The following is a description of a gene set: Human Gene Set: HP_URINARY_INCONTINENCE Urinary incontinence Loss of the ability to control the urinary bladder leading to involuntary urination. studied in species Homo sapiens, and this is the list of marker genes: MORC2, AP5Z1, CABP4, HTRA1 (NCBI Gene Id 5654), GALNT2 (NCBI Gene Id 2590), PIK3CA, SIGMAR1, FUS (FUS RNA binding protein), DNMT1, HPSE2, SPAST, SMO, CLCNKB, DEPDC5, SLC44A1, CACNA1H, PANK2, SLC2A1, IGHMBP2, CAPN1, NOTCH3, NOTCH2NLC, ARSA, MTMR14, SYNE1, GABRB3 (gamma-aminobutyric acid type A receptor subunit beta3), WASHC5, KCND3, ATXN10, AKT1 (NCBI Gene Id 207), SBF1, KIF5A, KMT2B, FITM2, SMARCB1, TRIO, HMBS, ZEB2, GABRA1, GALC, GABRG2, CHRNA4, CRH, ABCD1, SPG7, NEXMIF, TRPV4, BNC2, TBXT, BIN1, RETREG1, CPT1C, PDGFRB, SLC20A2, RSRC1, CACNA1G, VCP, SCN9A, ATP13A2, GBA2, MNX1, TBP, FRMD5, NGF, COG5, SMARCE1, ERLIN2, FMR1, GAA, NF2, STUB1 (STIP1 homology and U-box containing protein 1), ATXN8OS, TBCD, SLC9A6, ALS2, AUH, PRDM8, COPB1, ZC4H2, PSAP, FARS2, VPS13C (NCBI Gene Id 57581), MYO1H, SUFU, HEXB, HLA-DRB1, ZFYVE26, VANGL1, GJC2 (NCBI Gene Id 57165), SACS, SQSTM1 (NCBI Gene Id 94002), FUZ, ACBD6, SLC1A4, CHRNA2, FLVCR1, COQ2, ADNP, EIF2AK2, VANGL2, BAP1, ARX, SPTLC1, SPG11, GGT1, KCNT1, ZMYM2, LRIG2, DPH5, TRAF7, NEFL, HSPD1, KY, RYR1, PDGFB, FGFR3, RTN2 (reticulon 2), HLA-DQB1, HPS6, SLC12A3, TTR, CHRNB2 (cholinergic receptor nicotinic beta 2 subunit), DDHD2, CFAP43, DKK1, HS6ST2, CYP7B1, ATXN2, TERT, PEX11B, ATL1, NIPA1, ALDH18A1, MYF6, CHMP2B, ALMS1, FA2H, TIMM50, GBE1, RNF170, KCNC3, HACE1, POT1, JRK, CCL2, ENSG00000288330, TYROBP, IFT57, UBAP1, DNM2